The following is a description of a gene set: Human Gene Set: GOBP_CYTOKINE_MEDIATED_SIGNALING_PATHWAY The series of molecular signals initiated by the binding of a cytokine to a receptor on the surface of a cell, and ending with the regulation of a downstream cellular process, e.g. transcription. studied in species Homo sapiens, and this is the list of marker genes: MAP3K7, MIR125B1, IL4, SIN3A, CNTF, RAF1 (NCBI Gene Id 5894), MMP12, MAPK14, NLRC5, PPARG, TAX1BP1, APPL1, CBL, IL12B, IL7R, IL17RC, PXDN, PIAS3, CNOT9, GHR, CXCR2, METTL3 (methyltransferase 3, N6-adenosine-methyltransferase complex catalytic subunit), CDC37, TIFA, JAK1, IL2RB, ARG1, TNFRSF17, HPX, EPO, CCL15, CCL2, RRAGA, NR1H2, IL17RE, IFNL3, CCL4L2, IFNL4, RIPK1, UMOD, XCL1, IL5RA, OTULIN, MIR29B1, WNK1, IL20RB, LEP, SIRT1, IL22RA1, IL6ST, IFNA7, IL17RD, TNFSF11, NR1H3, MIR27A, LILRB1, EDAR, ST18, CCR4, TBK1, PRKN, MIB2, IL3RA, LILRB2, CREBRF, SHARPIN, CCL1, CCL19, TNFRSF11B, MED1, TRAF5, ADAM17, IL18RAP, TNFAIP3, ANXA4, IL9, ADAR, IL13RA2, STAP1, MKKS, PLP2, GPR17, CXCL11, IL34, LIFR, IL6, IL20RA, GPR108, IL11RA, PTPRC (protein tyrosine phosphatase receptor type C), CARD14, CCL11, IL33, IL1RN, CCL26 (NCBI Gene Id 155403), ZC3H15, IL4R (interleukin 4 receptor), TNFRSF19, EDA, ULK1 (NCBI Gene Id 8408), GSTP1, YTHDF2, STAT5B, STAT5A, EDA2R, IL15RA, SPATA2, TNFRSF1A, HDAC4, CRLF1, RPS6KA5, MIR125A, CTR9, RPS6KA4, EXT1, IL36RN, IL22RA2, CXCL6, IL13RA1, PALM3, IFNAR1, CCL7, ANGPT1, TRAF1, NSMAF, IFNA8, SOCS2, IL1RL1, IL21R, IL36A, MIR24-1, PYDC2, FAS, PTK2B, CCL5, CCR8, IL12RB1, MIR20A, WBP1L, USP18, DCST1, MIR101-1, SMAD4, GPR35, TNFSF13B, TNFSF18, CEBPA, AZI2, NLRP6, CD4, CARD8, IL1R1, F2RL1, OASL, TRAF2, LYN, CX3CL1, LILRA4, JAK3, CASP1, DNAJA3, CXCR6, TICAM2, IL15, MIR135A1, LAPTM5, IFIH1, PLVAP, MIRLET7A1, NKIRAS1, CARD16, MIR99A, RIPK2, BIRC2, TRIM44, IFNG, GPR75, TMSB4X, OTUD4, MIR98, UBE2K, SLIT3, TREX1, CD70, PIAS4, NOTCH1, EDN2, MIR21, ENTREP1, TTLL12, MAPKAPK2, SOCS1, CD40, IRAK1, IRAK3, EPG5, CCL14, TMC8, IL2RA, TNFRSF18, PPP2CB, IL17F, IL18, FOXO3, CCL16, MIRLET7E, RABGEF1, FLT3, BBS2, BAD, NR1H4 (NCBI Gene Id 9971), IRAK4, PRL, CXCL12, EIF5A, CCR10, IL23R (NCBI Gene Id 94006), IFNGR1, IFNA17, RHEX, OSMR, CD74, CCL24, KRT18, IL3, OSM, SOS1, JAGN1, NFKB1, ADIPOR1, F3, SP100, CCR5, TRAF6, ADAM10, SYK, OAS2, XCL2, ZBP1, CCR6, CXCR3, SOCS4, IFNA1, CACTIN, IKBKB, BIRC7, CCL4, ADIPOQ, LSM14A, STAT4, NFKBIZ, HCK, TYK2, ADIPOR2, MIR152, ROBO1, TNFRSF4, TNF, TNIP2, ACKR3, TP53, MX1, IL9R, SIGIRR, IRAK2, IRF5, CCL25, MST1R, CNOT7, DICER1, CD24, PTPN2, NR2C2, SPHK1, IFNB1, IL10, PARP9, IL36B, CR2, TNFRSF14, IFNA14, HIPK1, AKT1, IL36G, STAT2, AGPAT2, CSF2, MAVS, CIB1, TNFRSF11A, SPI1, SRC, GH1, SOCS5, CIITA, MIR130A, RELA, RFFL, CMKLR1, TANK, GPS2, OAS3, IL37, MUL1, PTPN11, LILRB5, TRADD, IL2RG, CLDN18, PAFAH1B1, IL7, IL13, SLIT2, IRS1, NFKBIA, CASP8, LILRA1, SLC27A1, TFF2, IL10RB, TRIM65, PTPN1, HSPA1A, PIK3R1, XIAP, USP27X, IL12A, GIGYF2, CSF3R, HAX1, CD300LF, PRLR, IKBKE, MIR34A, IL1R2, MIR1246, CXCR5, TRAF3IP2, IFNL1, LILRA3, CSNK2B, IFI27, CXCR1, IL1A, DAB2IP, KIT, EGR1, IL17A, ILK, ACSL1, COMMD7 (NCBI Gene Id 85361), HIF1A, IFNL2, IL1F10, YTHDF3, ACKR2, OAS1, CXCL10, SPPL2A, CPNE1, CCL3, ISG15, ACKR4, SH2B3, CAV1 (caveolin 1), IRF1, STAT6, FADD, NRDC (nardilysin convertase), TRAF3, AGPAT1, MIRLET7C, IL16, CXCL13, PYCARD, CCR3, IRF7, PDGFB, MYD88, OTOP1, PYDC1, CYLD, MPL (NCBI Gene Id 4352), RNF113A, NAIP, IL27RA, NUMBL, INHBA (NCBI Gene Id 3624), IFITM2, BBS4, IL5, MMP8, PTPRJ, H2BC11, CD44, GREM2, IL17RA, MAPK1, MIR520C, TRIM41, TNFRSF13C, P4HB, CTSG, CSF2RB, IL17RB, RBM15, TRIM32, YAP1, IFNA10, TXK, EBI3, EIF4E2 (eukaryotic translation initiation factor 4E family member 2), IL11, PRKACA, IL2, CCRL2, LEPR, USP29, MIR26A1, MAPK3, IFNA21, TRIM6, JAK2, IFITM3, TXNDC17, USP25, PF4, IRGM, CCR2, MT3, IL18R1, OXSR1, STAT1, CCL22, XCR1, ACKR1, NKIRAS2, C1QTNF4, CSF3, LIMS1, CNTFR, UGCG, IFNA2, CCL21, DOK1 (NCBI Gene Id 1796), IFNA4, LILRA5, SLC1A1, CSF1, CCL13, SOCS3, AIM2, P3R3URF, FER, LILRB4, TBKBP1, STK39, CDK5R1, SH2B2, CCL8, MIR146A, LILRA6, IFNW1, CCR1, IL1RAPL2, IL1RAP, IFNGR2 (interferon gamma receptor 2), PARP14, IL17REL, LILRB3, APPL2 (adaptor protein, phosphotyrosine interacting with PH domain and leucine zipper 2), EPOR, CRLF2, ECM1, EDN1, IFNA16, LILRA2, WNT5A, PELI3, VRK2, TRIM56, IL10RA, STAT3, NLRP2B, IFNAR2, APOA1, CISH, MIR27B, CASP4, PADI2, CCR9, IL31RA, FOSL1, PTPN6, TSLP, BIRC3, TNFRSF25, NOL3, SMIM30, IL1RL2, CHUK, CCL3L3, CSF2RA, LRP8, SRSF1, ACTN4, IFNLR1, CSF1R, IL1B, IL12RB2 (NCBI Gene Id 3595), SPPL2B, IFNA5, THPO, HCLS1, RNF185, IRF3, KRT8, HSPA1B (heat shock protein family A (Hsp70) member 1B), FZD4, IFNE, CLCF1, AXL, TREM2, DUOX2, IFNA6, STING1, CCDC3, TOLLIP, SAMHD1, IL6R, IFITM1, CX3CR1, CEACAM1, TRAIP, RBM47, CXCR4, CXCL9, FBXO21, CCL23, EREG, IFNK, TNFRSF1B, GAS6, GFI1, ZNF675, KRAS, FCER1G, DUOX1, CCR7, PLCB1, CCL18, FOXC1